The following is a description of a gene set: species: Mus musculus Mouse Gene Set: GOBP_ESTABLISHMENT_OF_PROTEIN_LOCALIZATION_TO_ORGANELLE The directed movement of a protein to a specific location on or in an organelle. Encompasses establishment of localization in the membrane or lumen of a membrane-bounded organelle., and this is the list of marker genes: Smurf1, Ift122, Shh, Nutf2, Pdcd5, Macf1, Fermt1, Pik3r4, Psen1, Timm50, Ipo5, M6pr, Nf1, Pex5l, Sec61a1, Ubl4a, Nup98, Tomm20l, Fbxo7, Tardbp, Prkcq, Hspd1, Nup153, Cd68, Sec61g, Sh3glb1, Akap1, Trp53, Gsk3a, Smo, Tram2, Srp54c, Ndufa13, Sumo1, Hyal2, Egf, Ipo4, Rab7, Vps54, Dkc1, Nup155, Prkcd, Tmco6, Mapk14, Prickle1, Tsc2, Lep, Gbp4, Get3, Fam53c, Nup93, Srebf1, Pom121l2, Nup107, Ptpn23, Pik3r2, Kpna2rt, Phip, Lrp2, Elavl1, Tnpo2, Kcnq2, Eif4enif1, Timm21, Maip1, Laptm5, Akirin2, Cox18, Pex1, Asb15, Spidr, Tert, Sirt6, Kpna4, Nutf2-ps1, Asb3, Atf2, Ect2, Egfr, Bag3, Aip, Tsg101, Arxes1, Vps37b, Igtp, Cdk1, Ssr3, Cct8, Tspan10, Clu, Lrwd1, Get4, Sec61b, Ufm1, Kpna3, Bag6, Glp1r, Vps25, Dnaja1, Vps4a, Rab10, Spg11, Vps53, Bid, Ptpn5, Folr1, Nup50 (NCBI Gene Id 69508), Pex26, Lamp2, Ubr5, Trim37, Wrap53, Stam, Tnfrsf1a, Rab3gap1, Tomm34, Ep300, Efcab7, Dmap1, Nutf2-ps2, Rala, Pola2, Vps37c, Lrrk2, Parl, Gfer, Dyrk1a, Agt, Spdya, Sec61a2, Mtch1, Spry2, Prkaa1, Nup88, Terf1, Nup214, Vps28, Hspa8, Akap5, Ddit3, Kpnb1, Chp2, Usp9x, Pdcd5-ps, Man1a, Chchd4, Ipo13, Mipep, Zfand6, Srprb, Fis1, Grpel2, Neurl3, Nup85, Bbc3, Nup62cl, Vps41 (NCBI Gene Id 64932), Kpna6, Tomm40, Stk3, Lamp5, Nup188, Dnajc15, Ei24, Bmpr1a, H1f5, Gper1, Irgm2, Traf3ip2, Cdh1, Timm17b, Tpr, Tram1, Prkd1, Tspan17, Sort1, Snx16, Gcc2, Golph3l, Eps15, Nedd4 (NCBI Gene Id 639396), Sqstm1, E2f3, Herpud1, Sh3kbp1, Sirt4, Timm17a, Ipo8, Hk2, Pex5 (peroxisomal biogenesis factor 5), Ddx5, Tomm40l, Vps8, Acd, Pkia, Dusp21, Nup62, Rasl2-9, Cfl1, Timm8a1, Bag4, Grb2, Tcp1, Stk4, Drd1, Pmaip1, Adar, Bmp2, Gckr, Gdap1, Srp14, Romo1, Abra, Sec63, Tomm22 (translocase of outer mitochondrial membrane 22), Sgta, Ipo11, Fgf9, Wbp2, Cd36, Brca1, Appl1, Nipbl, Notch1, Ranbp6 (RAN binding protein 6), Golph3, Sprn, Pam16, Ipo9, Pmpcb, Nol3, Mapt, Ifng, Zc3h12a, Il6, Timm22, Kpna1 (NCBI Gene Id 16646), Nup54, Rbm22, Macroh2a1, Mff, Rab23, Adcy10, Tnpo3, Vps37d, Pttg1ip, Zfyve16, Epm2a, Vps36, Tomm20, Ran, Sec62, Bax, Mmp12, Pex7, Zic1, Irgm1, Ncoa4, Timm23, Nup35, Srp19, Hspa4, Hsp90aa1, Flna, Lamp1, Macroh2a2, Il33, Srp72, Get1, Hikeshi, Hcls1, Agk, Cct6a, Syk, Aifm1, Bcl3, Hspa5, 1700009N14Rik, Appl2 (adaptor protein, phosphotyrosine interaction, PH domain and leucine zipper containing 2), Pex16, Jup, Sec13, Vps13d, Tomm7 (translocase of outer mitochondrial membrane 7), Kcnq3, Lyset (lysosomal enzyme trafficking factor), Nr4a1, Hsp90ab1, Mavs, Cry2, Phb2, Xbp1, Timm44, Uaca, Scarb2, Timm10, Agap3, Hacl1, Mfn2, Cabp1, Pik3r1, Mtch2, Sgtb, Tomm70a, Pot1b, Sorl1, Timm13, Srpra, Ing1, Tmem126a, Nabp2, Six3, Cct5 (NCBI Gene Id 12465), Vps13a, Spcs3 (NCBI Gene Id 76687), Pex12, Ppp3ca, Rpain, Folr2, Hnf4a, Rab3gap2, Agtr2, Ppp2r2b, Arxes2, Pex2, 4930550C14Rik, Ap3b1, Cse1l, Lmna, Grin2a, Ryr2, Nup50l, Mterf4, Pml, Trmt10b, Brca2 (breast cancer 2, early onset), Lonp2, Pex3, Cbl (Casitas B-lineage lymphoma), Txnip, Ipo7, Ptpn22, Bnip3l, Pom121, Cwh43, Kpna7, Samm50, Hgs, Zpr1, Srp54b, Akt1, Mdfic, Ap4m1, Rab8b, Fbxw7, Nos3, Immp2l, Lamp3, Hspa1l, Snupn, Ndp, Ywhab, Tnpo1, Pex19, Snf8, Zfp827, Pik3c3, Tgfb1, Neurl1b, Dnlz, Angpt1, Jak2, Timm9, Oxa1l, Bmp4, Pot1a, Hk1, Chmp4b, Grpel1, Six2, Nup58, Pink1, Hdac3, Ankrd10, Chp1, Stat3, Cubn, Srp54a, Med1, Spcs2, Pmpca, Immp1l, Pex10, Zdhhc15, Srp68, Cct7, Dnajc19, Lhcgr, Cdkn1a, Fam53b, Dusp18, Tek, Gli3, Nfatc3, Pex14, Pkig, Trim28, Heatr3, Bmpr2, Pttg1ip2, Atg14, Ap3d1, Mon1b, Nrarp, Cdkn2a, Tram1l1, Fam53a, Mapk1, Atp5if1, Nup133, Cct2, Gnptab, Vps13c, Bcap31, Mgarp, Cct3, Ranbp2, Bcs1l, Timm29, Bmal1, Becn1, Pex13, Mir208b, Spcs1, Pex6 (peroxisomal biogenesis factor 6), Gga3, Zfand2b, Tomm5, Rab11a, Ppp3r1, Nfkbia, Moap1, Hm629797, Kpna2, Tnfaip3, Srp9 (signal recognition particle 9), Ywhaz, Ankrd6, Mon1a, Nolc1, Ptgs2, Tspo, Cct4, AU015836, Apod, Vps37a, Lrsam1, Ruvbl2, Ctcfl, Zfand2a, Edem1, Siah3, Il10ra